The following is a description of a gene set: species: Mus musculus Mouse Gene Set: GOBP_REGULATION_OF_DOPAMINE_RECEPTOR_SIGNALING_PATHWAY Any process that modulates the frequency, rate or extent of a dopamine receptor signaling pathway activity. A dopamine receptor signaling pathway is the series of molecular signals generated as a consequence of a dopamine receptor binding to one of its physiological ligands., and this is the list of marker genes: Palm, Drd2, Cav2, Vps35, Lrrk2, Alk, Drd3, Rgs8 (regulator of G-protein signaling 8), Rgs4, Dtnbp1 (NCBI Gene Id 94245), Prmt5 (protein arginine N-methyltransferase 5)